Given this list of marker genes BIN1, NAA80, CKAP2, CYFIP2, CFL2, FHOD1, ARHGAP40, SVIL, ARAP1, FER, SLC9A1, GIT1, ASAP3, MIR1-1, ADD2, APC2, MAGEL2, ABL1, SPTAN1, SORBS3 (sorbin and SH3 domain containing 3), CLASP1, SSH2, CCDC88A, CX3CL1, AVIL, CAMSAP1, ARHGAP18, SPTBN4 (spectrin beta, non-erythrocytic 4), PXN, RHOA, ABI2, CAMSAP3 (calmodulin regulated spectrin associated protein family member 3), TPM1, IAPP, APOE, PTGER4, WASHC4, TUBB4A, CHADL, CCL26, HCLS1, SPTBN5, WASHC1, ATXN7, CORO2B, CAV3, WDR47 (NCBI Gene Id 22911), PRKN, C15orf62, ABITRAM (NCBI Gene Id 54942), LMOD1, LATS1, TACR1, WDR1, MIR20A, SEMA5A, MIR29B1, PRKD1, TMOD1, TWF1, SLC39A12, TGFB3, RAC1, USP8, AURKB, TRIOBP, PFN3, COTL1, TMSB4X, GPX1, CCDC88C, HAX1, CDC42EP5, CFL1, SWAP70, SLAIN2, NRP1, MET, PTK2B, ACTN2, ARHGEF2, WAS, PPP2CA, HAUS8, HDGFL3, BAIAP2L2, CLASP2, SMAD4, CDC42EP1, GAS2L1, PPM1F, MAP6D1, DLC1, NF2, RB1, DCTN1, F11R, NCK1, PRKCE, PFDN6, HSPA1A, NCKAP1L, FCHSD2, SSH3, SH3BP1, CTTN, ARHGAP6, DIAPH3, CORO1A, SYNPO2L, SHANK1, MTOR, AMOT, FCHSD1, EML2 (NCBI Gene Id 24139), SLAIN1, HAUS3, HDAC6, CIB1, TOGARAM1, KANK3, TACSTD2, PPM1E, AKAP9, COLGALT1, CLIP3, WNT4, SFRP1, NCKAP1, RGS4, BAIAP2L1, PLEKHG2, TPX2, ELN, KANK2, CDK5RAP2, DRG1, CARMIL1, PARK7, CSF3, ARHGEF10L, TMOD4, CCL11, PSRC1, ARHGAP35, BBOF1, PSEN1, CYFIP1, HAUS2, RGCC, NME7, TRPV4, CAPZA1, CAPZB, CKAP5, CDKN1B (cyclin dependent kinase inhibitor 1B), KIRREL1, ARF6, TWF2 (NCBI Gene Id 11344), VASP, PAK3, SMAD3, SPTBN1, OCLN, WASHC2A, SDC4, CD47, ARHGEF7, PFDN2, APC, ARHGEF10, STMN2, ADD1, SCIN, CARMIL3, MIR31, FGF13, ALOX15, CCN2, TAC1, TMEFF2, CARMIL2, CCL24, ARF1, XIRP2, NUMA1, CYRIA, WASHC2C, PFN2, ROCK2, TBCD, BMERB1, CDC42EP2, MYOC, LIMCH1, CLU, PYCARD, NAV3, WASF3 (NCBI Gene Id 10810), CDC42EP3, S1PR1, SPTB, RASA1, SYNPO2 (NCBI Gene Id 171024), MTPN, ASB2, PIK3R1, CDC42EP4 (CDC42 effector protein 4), GAS2L2, AP1AR, DNAI3 (dynein axonemal intermediate chain 3), INPP5J, RNH1, PIK3CA, GMFG, PFN1, ARHGEF18, COL6A1 (NCBI Gene Id 1291), MID1IP1, WASH3P, GMFB, ANKRD23, GSN, LIMA1, RHOC, CDH5, HAUS4 (HAUS augmin like complex subunit 4), EVL, MECP2, PAK2, GPR65, HCK, ARHGAP28 (NCBI Gene Id 79822), CDC42, TJP1, HAUS5, ARL2, SHANK3, VILL, DAAM2, NCK2, EMILIN1, DYRK1A (NCBI Gene Id 1859), FES, HSPA1B, AEBP1, SNX9, MAPRE3, PRKCD, CAPG, BMP10, ARFGEF1, ARPIN, WASH6P, KANK4, RPS3, FKBP4, STMN1, ANKRD53, APP, ARFIP1, SYNPO, SPEF1, DSTN (destrin, actin depolymerizing factor), LMOD2, WASHC5, WASF2, CRYAB, FLII, ARHGEF5, FERMT2, SSH1, MTSS1, ARHGEF15, CRACD, MIR149 (NCBI Gene Id 406941), TTC8, RDX, ARPC3, SPAST, HSPA8, KATNB1, GBA2, PDE4DIP, SPTBN2, CAPZA3, TESK1, BBS4, SLIT2, MIR21, ROCK1, PRUNE1, CYRIB, EFEMP2, DMTN, DAPK3, RICTOR, FLNA, ARPC5L, ARFIP2, FRMD7, MAP1S, EDN1, MAP2, TTBK2, PICK1, MAPT, INPPL1, MAP1A, SKA1, LPAR1, PIK3R2, HAUS1, HAUS6, CDK5R1, TRIM54, NPHS1, TSC1, GRB2 (growth factor receptor bound protein 2), PROX1, PAK1, PDXP, PREX1, HAUS7, ITGB1BP1 (NCBI Gene Id 9270), CHRNA7, CLIP1, MIR214, TOGARAM2, CORO1B, ACTG1, MAPRE1, F2RL1, TMOD2 (NCBI Gene Id 29767), WASF1, SPTA1, PLEK, APOA1, PPFIA1, DLG1 (discs large MAGUK scaffold protein 1), BRAF, MAP1B (microtubule associated protein 1B), TGFBR1, PFDN4, TENM1 (teneurin transmembrane protein 1), KANK1, PPP2CB, PLEKHH2, CGNL1, HIP1R, RHPN2, MLST8, S100A10, OAZ3, SPECC1L, TMSB4Y, KIF21A, VBP1, LDLR, HSPG2, RHPN1, LMOD3, BAG4, BRK1, TAOK1, SERPINF2, MIR138-1, TREM2, WHAMM, CCR7, MID1, AKAP13, CXCL12, ADD3, MYADM, LIMK1, TRIM27, RHPN2P1, TMOD3, ESAM, RAPGEF3, ARPC2, EPHA1, PHLDB2, ALMS1, PFDN5, CCL21, WASHC3, C9orf72, INPP5K, CAPZA2, MYLK3, SNCA, CTNNA2, CAMSAP2, BAIAP2, ARPC5, VIL1, EPS8, TNXB, MKKS, PFDN1, here is a description of the gene set: species: Homo sapiens Any process that modulates the frequency, rate or extent of supramolecular fiber organization. Human Gene Set: GOBP_REGULATION_OF_SUPRAMOLECULAR_FIBER_ORGANIZATION